Given this list of marker genes CIROP, MED25, PRKACB, ZIC3, SLC29A3 (NCBI Gene Id 8072), here is a description of the gene set: species: Homo sapiens Human Gene Set: HP_LEFT_SUPERIOR_VENA_CAVA_DRAINING_TO_CORONARY_SINUS Left superior vena cava draining to coronary sinus A persistent left superior vena cava (PLSVC) that drains into the right atrium via the coronary sinus. This is the case in 80-92% of cases of PLSVC and results in no hemodynamic consequence.